The following is a description of a gene set: A protein complex that forms a transmembrane channel through which calcium ions may pass in response to changes in membrane potential. studied in species Homo sapiens Human Gene Set: GOCC_VOLTAGE_GATED_CALCIUM_CHANNEL_COMPLEX, and this is the list of marker genes: CACNG2, CATSPERE, CACNA1S, CATSPER2, PDE4D, CATSPERB, CACNB2, CACNA1E, CACNA1C, EFCAB9, CACNA2D2, CATSPER3, CACNG1, CATSPERD, STAC3, CACNB3, CATSPER1, CACNG8, CATSPER4, CACNG4, CACNA1B, CACNB4, CACNA1A, TMEM262, CACNA1G, HSPA2 (NCBI Gene Id 3306), CACNG6, FKBP1A, CACNA1I, CACNA2D4, TMEM249, CACNA1H, C2CD6, CACNG3, RYR1 (NCBI Gene Id 906), CATSPERG, CACNB1, CACNA1F, CACNA2D3, CATSPERZ, CACNG7, CACHD1, CACNA2D1, CACNA1D, PDE4B